The following is a description of a gene set: studied in species Mus musculus Any process that results in a change in state or activity of a cell (in terms of movement, secretion, enzyme production, gene expression, etc.) as a result of an angiotensin stimulus. Angiotensin is any of three physiologically active peptides (angiotensin II, III, or IV) processed from angiotensinogen. Mouse Gene Set: GOBP_CELLULAR_RESPONSE_TO_ANGIOTENSIN, and this is the list of marker genes: Fam114a1, Mas1, Rock1, Ppp3ca, Agtr1b, Rock2, Slc30a10, Inhba, Car2, Prkca, Kdm6a, Ddr2, Cav1, Agtrap, Rac1, Src, Prkcd (protein kinase C, delta), Actn2, Nr3c2, Rela, Agtr1a, Agtr2, Ace, Agt, Sirt6 (NCBI Gene Id 72769), Nfe2l2, Rap1gds1, Prkd1, Ahcyl1, Hsf1, Nono, Brip1, Nfkb1, Ptpn1, Map3k7, Ang2, Slc26a6, Camk2a